The following is a description of a gene set: species: Mus musculus Mouse Gene Set: GOBP_POST_EMBRYONIC_DEVELOPMENT The process whose specific outcome is the progression of the organism over time, from the completion of embryonic development to the mature structure. See embryonic development., and this is the list of marker genes: Aldh5a1, Ehbp1l1, Usp9x, Itpr1, Abl1, Fgfr2 (fibroblast growth factor receptor 2), Ercc1, Csrnp1, Dnmt3l, Fzd5, Dhcr7, Acvr2b, Kmt2a (lysine (K)-specific methyltransferase 2A), Ireb2, Ash1l, Ahr, Plagl2, Krtap21-1, Mecom, Atrx, Kdr, Nr4a2, Chaserr, Grcc10, Heg1, Sod2, Flt3, Bmp4, Nkx2-3, Nppc, Igf2r, Morc3, Mir34b, Jak2, Enpp1, Schip1, Atn1, Tmtc3, Stk36, Myl2, Foxp2, Gnas, Klf4, Invs, Ndn, Selenop, Mir23a, Gnaq, Gata3, Zfp950, Mir449c (NCBI Gene Id 735309), Vps54, Serpina7, Large1, Ccdc47, Apob, Abl2, Cyp1a2, Acadm, Bax, Plekha1, Ago2, Asl, Slc37a4, Scn9a, Mapk8ip3, Zfx, Myt1, Crb1, Flt1, Tgfbr1, Sox6, Aco1, Tiparp, Szt2, Dicer1, Pnlip, Atm, Hmgn1, Mnx1, Cela1 (NCBI Gene Id 69846), Tet2, Kat8, Bak1, Tcf7l2, Serp1, Dscam (NCBI Gene Id 78761), Grk1, Emx1, Ppp1r13l, Rc3h2, Gnasas1, Sgpl1, Alx4, Mir449b, Rab3a, Mmut, Mtor, Mir449a, Inppl1, Kdm5b, Eva1a, Gigyf2, Lhx1, Fendrr, Chst11, Mir34c, Prdm1, Helt, Vegfa, Ercc2, Mecp2, Bcl2, Atf5, Dnmt3a, Slc18a2, Psen1, Sema3c, Terc, Meg3, Bpnt2, Atg7, Dlk1, Tbce, Trp73, Siah1a, Slc4a10, Llgl2, Arid5b, Etnk2, Smad2, Slc8a1 (solute carrier family 8 (sodium/calcium exchanger), member 1), Gabrg2, Kcnj1, Bcl11b, Bcl2l11, Myo1e, Cfc1, Tal2